Given this list of marker genes Trmt2b, Zcchc4, Fdxacb1, Bud23, Nsun5, Dimt1, Tfb2m (transcription factor B2, mitochondrial), Nop2, Nsun4, Tsr3, Mettl15, Fbl, Tfb1m, Mrm1, Mrm3, Emg1, Fbll1, Mrm2, Mettl5, Ftsj3, here is a description of the gene set: Catalytic activity that acts to modify a ribosomal RNA. studied in species Mus musculus Mouse Gene Set: GOMF_CATALYTIC_ACTIVITY_ACTING_ON_A_RRNA